Given this list of marker genes Eif4g3, Npr3, Drd2, Pde6b, Qpct, Adra2c, Slc16a12, Vsir, Adcyap1, Serpine2, Ssbp2, Arnt2, Fabp4, Ephb6, Popdc3, Cd302, Pabpc4l, Kcnab1, Pla2g7, Car13, Gpr153, Xpo7, Rims4, Eva1a, Hecw1, Lxn, Loxl2, Cd74, Perp, F5, Fbxo45, Fgf9, Cyp2b10, Cdc14a, Eva1b, Med13, Rab9b, Pdxp, here is a description of the gene set: Up-regulated genes from the set D (Fig. 5a): specific signature shared by cells expressing MLL-AF4 alone and those expressing both MLL-AF4 and AF4-MLL fusion proteins. The reciprocal chromosomal translocation t(4;11) is correlated with infant, childhood, adult and therapy-related high-risk acute leukemia. Here, we investigated the biological effects of MLL.AF4, AF4.MLL or the combination of both reciprocal fusion proteins in a conditional in vitro cell culture model system. Several parameters like cell growth, cell cycling capacity, apoptotic behavior and growth transformation were investigated under physiological and stress conditions. Co-transfected cells displayed the highest resistance against apoptotic triggers, cell cycling capacity and loss-of-contact inhibition. These analyses were complemented by gene expression profiling experiments and specific gene signatures were established for each of the three cell lines. Interestingly, co-transfected cells strongly upregulate the homeobox gene Nanog. In combination with Oct4, the Nanog homeoprotein is steering maintenance of pluripotency and self-renewal in embryonic stem cells. Transcription of Nanog and other stem cell factors, like Oct4 and Bmi1, was verified in biopsy material of t(4;11) patient cells which express both reciprocal t(4;11) fusion genes. In conclusion, the presence of both reciprocal MLL fusion proteins confers biological properties known from t(4;11) leukemia, suggesting that each of the two fusion proteins contribute specific properties and, in combination, also synergistic effects to the leukemic phenotype. Mouse Gene Set: GAUSSMANN_MLL_AF4_FUSION_TARGETS_D_UP species: Mus musculus from publication Gaussmann A, Wenger T, Eberle I, Bursen A, Bracharz S, Herr I, Dingermann T, Marschalek R (PMID 17130830)